The following is a description of a gene set: Genes up-regulated in comparison of CD4+ CD8- thymocytes versus CD4- CD8+ thymocytes. species: Homo sapiens Human Gene Set: GSE31082_CD4_VS_CD8_SP_THYMOCYTE_UP Mouse thymocytes can be classified into four major subsets based on expression of CD4 and CD8 co-receptors. CD4-CD8- (double negative, DN) cells become CD4+CD8+ (double positive, DP) cells following productive T cell receptor (TCR) beta chain rearrangement. A small proportion of DP cells are selected through interaction of clonal TCRalpha/beta and MHC self peptide complex expressed on thymic stromal cells. DP cell expressing MHC class I-restricted TCR become CD4-CD8+ cells, which will finally differentiate into cytotoxic T cells, while MHC class II restricted selection generates CD4+CD8- helper lineage T cells. We used microarrays to identify genes important for thymocyte differentiation and lineage determination by profiling gene expression in different thymocyte subsets. from publication Egawa T, Littman DR (PMID 21873191), and this is the list of marker genes: IFNGR2, SEC24D, PAN3, WASHC4, HMG20A, IGFBP4, SMIM13, NUFIP2, PLEKHG2, STK26, CAST, IL6R, AVL9, JARID2, NFATC2, ZCCHC12 (zinc finger CCHC-type containing 12), FBXO38, LSM14A, RAP2C, DDX17, ZMAT1, TESC, AKT3, TRPM7, TOB1 (transducer of ERBB2, 1), WBP1L, ZBED6, TBL1X, BIRC3, MRGBP, ZDHHC17, UBE4B, ZNF362, PIP4K2A, SCRIB, SLC35A1 (solute carrier family 35 member A1), HP1BP3, GALNT6, KLHL17, SYTL2, NEK4, GPR146, GYPC, TET1 (NCBI Gene Id 80312), CKB, ARHGEF10, DNAJC6, LNX2, CHD3, ST6GAL1, INPP4B, ETS1, AP1B1, ZMAT3, AAK1, LRP8, DLG3, DOLPP1, NR4A1, IPO8, IL21, HEXIM1, TMEM154, PITPNM1, PRDM1, MYO10, SLC25A45, C1QTNF12, RGS14, PIK3R3, SLC36A1, ZBTB7B, KDM4A, KMT5B, PYGO2, INPP5F, PLXND1, F13A1, PDHA1, ARMCX6, FOXN3, MPZL3, RASGRP1, TRIM24, MTHFR, TMEM87B, CD5, HSDL1, DUSP1, RAPGEF2, PHEX, CD81, CAMTA2, CPEB4, CRYBG1, YPEL2, TGFBRAP1, HDAC5, SLC30A5, DENND11, PPM1B, RAB5B, CD2AP, KRBA1, MBTPS1, CAMKK2, MRTFB, NCMAP, RREB1, RAB6A, PTGR1, CLCN4, PAQR3, POGK, HECA, UBE3B, LTC4S, BCL9, LGALS3, LDB1, PCNX1, CD247, RCOR3, IFI44, PPP4R3A, RSF1, FKBP1A, TTYH3, CITED2, OSBPL9, TRIM34, ROCK1, DOK2 (NCBI Gene Id 9046), XPO6, TMEM35A, CD274, LYSMD3, TXNDC16 (NCBI Gene Id 57544), NXPE3, DUSP11, SERINC4, EPHB6, ERC1, ASB2, RALGPS2, TSC1, ITIH5, GNAQ, BCL2A1, FHIP2B, ABHD17C, CCDC186, SH3BP2 (NCBI Gene Id 91018), IGF2R, SECISBP2L, HIVEP1, ZFP91, SETD1B, IKBKE, SWAP70, NNT, JMJD1C, WDR26, EXOC6B, RAP1A (RAP1A, member of RAS oncogene family), MFSD6, DUSP5, GALNT7, ALDH2, SALL2, HACD3 (NCBI Gene Id 95112), ARHGAP5, PTMS, TRIB2, EID1, MAN2C1, MAML1 (mastermind like transcriptional coactivator 1), SLMAP, GALNT10, SERINC5 (NCBI Gene Id 256987), ARHGEF6, USP34, PTGER4, DAAM1, AKAP12 (NCBI Gene Id 9614), PWWP2A, IGSF23, ASCC3, UPF3B, IL4, MLLT3, CASD1, TNPO2, SFMBT2, CCR4, IL17RB, RGL2, PTGIR, DENND6A, TRAT1